The following is a description of a gene set: species: Homo sapiens An anomaly of the metaphysis of the distal femur (close to the knee). Human Gene Set: HP_ABNORMAL_DISTAL_FEMORAL_METAPHYSIS_MORPHOLOGY Abnormal distal femoral metaphysis morphology, and this is the list of marker genes: BMP1, COL10A1, PAM16, EZH2, GNPNAT1, SETBP1